Given this list of marker genes Pik3r5, Pik3c3, Atm, Pik3r2, Pik3ca, Pik3r1, Pik3cg, Pik3r6, Pik3c2g, Pik3cd, Pik3c2b, Pik3cb, Pik3c2a, Pik3r3, here is a description of the gene set: Catalysis of the reaction: a 1-phosphatidyl-1D-myo-inositol + ATP = a 1-phosphatidyl-1D-myo-inositol 3-phosphate + ADP + H+. species: Mus musculus Mouse Gene Set: GOMF_1_PHOSPHATIDYLINOSITOL_3_KINASE_ACTIVITY